The following is a description of a gene set: species: Mus musculus The progression of the diaphragm over time from its initial formation to the mature structure. The diaphragm is a skeletal muscle that is responsible for contraction and expansion of the lungs. Mouse Gene Set: GOBP_DIAPHRAGM_DEVELOPMENT, and this is the list of marker genes: Gata4, Wt1, Tcf21, Ass1, Disp1, Stra6, Mnx1, Fgfrl1, Myt1, Msc, Fkrp